The following is a description of a gene set: Human Gene Set: GOBP_REGULATION_OF_CENTROMERIC_SISTER_CHROMATID_COHESION species: Homo sapiens Any process that modulates the frequency, rate or extent of sister chromatid cohesion in the centromeric region of a chromosome., and this is the list of marker genes: CTNNB1, BUB1, AXIN2, NAA10, CTCF